The following is a description of a gene set: Genes down-regulated in comparison of dendritic cells (DC) exposed to L. donovani versus DCs exposed to L. major. Monocyte-derived dendritic cells (DC) and macrophages (MΦ) generated in vitro from the same individual blood donors were exposed to five different pathogens, and gene expression profiles were assessed by microarray analysis. Responses to Mycobacterium tuberculosis and to phylogenetically distinct protozoan (Leishmania major, L. donovani, Toxoplasma gondii) and helminth (Brugia malayi) parasites were examined, each of which produces chronic infections in humans yet vary considerably in the nature of the immune responses they trigger. studied in species Homo sapiens Human Gene Set: GSE360_L_DONOVANI_VS_L_MAJOR_DC_DN from publication Chaussabel D, Semnani RT, McDowell MA, Sacks D, Sher A, Nutman TB (PMID 12663451), and this is the list of marker genes: TXNRD2, ZNF45, ECPAS, SREK1, HNRNPL, CASP4, KDSR (NCBI Gene Id 2531), C5orf15 (chromosome 5 open reading frame 15), LMNA, GRINA, SSNA1, RNF187, PADI2, BCL2A1, POU4F2, CLCN3 (chloride voltage-gated channel 3), SFSWAP, TMEM186, MYO1A, SLC4A1, BRWD1, HGD, MTERF1, CDC6, SGCG, CLIC1, SORBS3, LSR, CDC5L, UGP2, SVIL, HERC2P3, ADH1A, RNF19B, DUSP1, CPA3, CTDSP2, KLC1, SLCO1B1, DOCK1, HPS5, FOSL1 (FOS like 1, AP-1 transcription factor subunit), DOCK4, ICAM5, COIL, PTPN13 (NCBI Gene Id 5783), CERS6, IRS1, SEC61A1, ARSA, ISCU, HLX, SH3GL1 (SH3 domain containing GRB2 like 1, endophilin A2), ITGA2B, UBB, PSD3, CNOT3 (CCR4-NOT transcription complex subunit 3), CNPY2, CD5, SLC38A10, EXPH5, SLC35D1, HLA-A, BCL2, LY6E, PGRMC2, WTAP, BCAM, VAT1, RNF10, VSIG4, PTS, PLXNC1, CLINT1, SPAG8, TCHH, CNTN2, SLC19A1, CHRNA1, USP15, ZMYND10, CCS, DAO, TAF9, UBOX5, GPS2, TNR, ARRB2, ADAM8, METTL3, GADD45G, HSDL2, CPLX2, IL17RA, TUBB4B, GRIK1, XCL1, KLF6, HGFAC, COL6A2, SLC25A12, CHD2, PPP1R3D, ATP1A3, IL10, PPP2R5B, PITX2, CGREF1, PEG10, RALGDS, MEOX1, CITED1, GPR50, HCG9, RECQL5, CHKB (NCBI Gene Id 1120), CLCA1, GNAT2, CRAT, RRAS, USF2, PART1, USP12, ZFP36, ASF1A, POU3F2, VWF, DPYSL3, PSMD8, NR4A3, MTCL2 (microtubule crosslinking factor 2), TRADD, UBE2M, LIG4, ENO1, EVPL, KLHL9, CENPB, RB1CC1, EEF1B2, GPC1, CACNA1H, FAM153A, DYNLT1, GALC, DEPDC5, RHOBTB2, SSR4, CMA1, CXCL11, GAS8, OPA1, MTHFR, VAPB, POU3F1, IDS, TMPRSS11D, GNB2, HMMR, RXYLT1, PLLP, CRIM1, COLQ, MUC1, CHD5, MYCNOS, TFAM, DENND4A, CCL21, CD70, S100A8, HMX1, HSD11B1, ALDH3B1, RAPGEF1, CDH5, SOCS7, HINFP, SCCPDH, YWHAH-AS1, LPAL2, SRP54, LRRC14, GPD1L, VEGFD, RFPL3S, SLC1A5, FOLR1, RTN2, ATP8B1, DNAJC16, HECTD4, IFI6, TRIB1, ATF3, CBX5 (chromobox 5)